Given this list of marker genes PRDX1, DEPDC5, SDHAF2, SDHC, HNF4A, RET, RPL5, GATA1, GATA2, ABCB7, FH, FANCA, LIN28B, RPS27, AMN, ENG, KCNJ11, BMPR1A, HMGCL, ALAS2, TMEM126A, PCDH19, LRAT, SRSF2, AIP, GABRA1, HEATR3, GABRB3, RPL18, SMAD4, SNX10, ANK1, AGBL5, RPL9, STEAP3, RPL26, RPL15, SPTB, POMGNT1, CACNA1H, FANCC, NPRL2, ZNF699, VHL, RAG2, CDH23, FANCD2 (FA complementation group D2), JAK2, RAX2, RPS28, YARS2, KIT, RPS24, UCP2, SLC4A1, HBG1, RPS26, MSTO1, IKBKG, TMEM127, CASK, ALK, TET2, HBG2, MYD88, NF1, MYCN, MMACHC, SCN1A, RPS19, HBB, RPL35, RPS29, GABRG2, ASXL1, FANCE, WDR19, HACE1, TMPRSS6, SLC2A1, FBP1, CLCN7 (chloride voltage-gated channel 7), PUS1, SDHA, SF3B1, DNMT3A, RPS15A, DLST, ATP1A3, G6PD, HEXA, SDHB, HBA2, CALR, ATP1A2, SPTA1, SLC46A1, PIGA, TSR2, RPS10, JRK, SLC1A3, EPB41, MAX, RPS7, SH2B3, COL12A1, SCN1B, PKLR, RACGAP1, KIF1B, RPL35A, MEN1, ACAT1 (acetyl-CoA acetyltransferase 1), SLC25A11, EPAS1, PTS, KIF23, OPA1, TCIRG1, MPL, SLC19A2, PHOX2B, RPL27 (NCBI Gene Id 6155), DHFR, MDH2, ABCC8, RPL11, SCN9A, RPL31, CACNA1A (NCBI Gene Id 773), RPS17, KLF1, RPL8, HNF1A, TTC8, CDIN1, CCND1, TNFSF11, ALS2 (NCBI Gene Id 65058), LMO1, SDHD, HBA1, ADA2, KCNQ2, RPS20, MMADHC, CDH3, RAG1, EPB42, PIEZO1, SCN2A, NPRL3, CUBN, MT-CYB, here is a description of the gene set: species: Homo sapiens Human Gene Set: HP_PALLOR Abnormally pale skin. Pallor